Given this list of marker genes DACT2, DAND5, NOMO1, NOMO3, NCLN, here is a description of the gene set: Any process that stops, prevents or reduces the frequency, rate or extent of nodal signaling pathway. Human Gene Set: GOBP_NEGATIVE_REGULATION_OF_NODAL_SIGNALING_PATHWAY studied in species Homo sapiens